The following is a description of a gene set: Human Gene Set: MIR518A_5P_MIR527 Genes predicted to be targets of miRBase v22 microRNA hsa-miR-518a-5p, hsa-miR-527 in miRDB v6.0 with MirTarget v4 prediction scores > 80 (high confidence targets). species: Homo sapiens from publication Chen Y, Wang X (PMID 31504780), and this is the list of marker genes: CHIC2, CNIH4, NUP54, ECT2, TEAD1, FOXO3, CDR2, AGO3, CGN, ELFN1, UBE2A, RNF38, QKI, PCDH7, CDYL2, PRKX, GPR85, INSYN2A, MEF2C, CBLN1, GBP5, RPP14, SUPT16H, KCNA1, JAM2, C1orf21, PHF12, NR3C2, TLE4, SPRR2E, SLC4A7, ZBTB46, KCTD20, RAB8B (RAB8B, member RAS oncogene family), ADGRG2, TMEM163, SLC35D1, TMEM135, TMEM123, RBFOX2, ZEB2, SATB2, NWD2, TBX4, NHLRC2, OGDH, SLC35A3, BNC2, PDZRN3, ENPP5, FOXN3, CTBS, GTDC1, AQP8, IL1R1, MAFK, PNN, WDR47, SH3D19, KMT5B, SYNPO2, CREBRF, ARID4A, MAP1LC3B2, STAG2, CRISPLD2, SENP1, HOOK3 (NCBI Gene Id 84376), KCTD21, KCNA4, SPO11, ENTPD1, PCBD1, TARDBP, AEBP2, MSL2, EGR4, ARK2N, PIK3R1, HNRNPUL1, TBX15, TRIM23, PFN2, ANGPTL1, IMPA1, RFC1, NPHP3, HIPK3, VAMP4, PARP8, INO80D, EPB41L1, TNC, TNRC6B, RNASEH2B (ribonuclease H2 subunit B), FUNDC1, XKR4, UBE2D2, NPEPL1, CNOT7 (NCBI Gene Id 29883), PRUNE2, NECAP2, KLK12, XPR1, RMND5A, MIER3, PHF6, ZFHX3, ZC4H2, ID2, ANK3, ACVR1, DTX2, ZDHHC21, LSM11, PLCB1, ACSL6, PLXNA2, FZD4, RHOB, SALL1, CCNK, DCK, RORA, PFKFB4, PSD3, DCUN1D4, ZFAND6, ZNF521, KPNA4, UBE2G2, TNRC6C, ATP5MG, POLR2M, MAPK6, ATXN1, NSG1, GNAI3, FBLN5, ZBTB20, KLHL13, GTF2A1, NFKBIZ, KRTAP9-4, FRYL, RNF14, CNKSR2, PDCD6IP, LAMTOR3, TCF4, FYTTD1, PLPPR5, STXBP5L, ATXN10, TUBE1, EDIL3, WIPI2, NUS1, PUS7, CA3, ATP11C, SRSF7, ELFN2, ISM1, PSMD5, RAP1A, SGK1, PDE4D (phosphodiesterase 4D), PPP1R15B, SLC22A2, RBKS, SENP7, ADGRA2, LFNG, CYSLTR1, SLC35A5, DCLK1, HTR2C, OTUD1, KLF12, S100G, LATS1, GOLGA5, NAA30, HBEGF, CLCN3, KRTAP9-3, RARG (retinoic acid receptor gamma), TMEM106B, LRP6, CFAP300, HDAC2 (NCBI Gene Id 3066), SREK1IP1, BICD2, DSCAM, LRATD1 (NCBI Gene Id 654112), EPHA5, MRPL35, ABHD5, CCNYL1, SOCS3, CDH11, RBMS2, PRKAR2B, GPR158, NAALADL2, MCC, MMP24, ZMAT3, TNPO1, PALLD, GCOM1, CDHR3, BTC, AMER2, THSD7A, FAM168A, EZH2, CXXC4, A1CF, STK4, CEP350, GET1, MCOLN3, SEL1L3, ULK1, STRN, THRB, MAP6D1, DCP1A, CYP2E1, MAP1LC3B, GRM7, EFNA5, KCNIP4, FBXO28, AKIRIN1, GUCY1A2, PAN2, ELK4, SERINC5, JRKL, MACROH2A1, ARPC2, DPP10, PREP, IMPDH1, OTUD4 (OTU deubiquitinase 4), RACGAP1, MAT2B, TRPC3, WNT3, ROBO1, WASF3, SAMD4A, NANP, ANKRD10, SLC30A7, ACSL4, PDGFD, KDM2A, KDM7A